Given this list of marker genes TRIM37, HDAC6, PRKN, UBD, BAG3, VCP, here is a description of the gene set: The aggregation, arrangement and bonding together of a set of components to form an aggresome; requires the microtubule cytoskeleton and dynein. studied in species Homo sapiens Human Gene Set: GOBP_AGGRESOME_ASSEMBLY